Given this list of marker genes BATF3, TCF4, SPI1, CSF2, FLT3LG, CSF1, IKZF1, STAT3, IRF4, RUNX2, ID2, IRF8, TPO, here is a description of the gene set: Human Gene Set: WP_DEVELOPMENT_OF_PULMONARY_DENDRITIC_CELLS_AND_MACROPHAGE_SUBSETS Development of pulmonary dendritic cells and macrophage subsets studied in species Homo sapiens